The following is a description of a gene set: Mouse Gene Set: REACTOME_TIE2_SIGNALING species: Mus musculus Tie2 Signaling, and this is the list of marker genes: Pik3r2, Sos1, Grb7, Angpt4, Grb14 (NCBI Gene Id 99012), Angpt1, Pik3cb, Grb2, Dok2, Pik3ca, Angpt2, Hras, Tek, Ptpn11, Kras, Shc1, Pik3r1